The following is a description of a gene set: Human Gene Set: GOBP_REGULATION_OF_ANTIMICROBIAL_PEPTIDE_PRODUCTION Any process that modulates the frequency, rate, or extent of antimicrobial peptide production. species: Homo sapiens, and this is the list of marker genes: EVPL, KLK3, IL17A, KLK7, IL17F, PGC, SPINK5, KLK5